Given this list of marker genes HOXA9, MID1IP1, NDUFA4, POLR3F, NDRG4, BDNF, here is a description of the gene set: studied in species Homo sapiens from publication Chen Y, Wang X (PMID 31504780) Human Gene Set: MIR147B_3P Genes predicted to be targets of miRBase v22 microRNA hsa-miR-147b-3p in miRDB v6.0 with MirTarget v4 prediction scores > 80 (high confidence targets).